Given this list of marker genes Pdcd1, Ptpn11, Trbv16, Trav16, Trav19, Pdcd1lg2, H2-Eb1, Cd3d, Cd3e, H2-Ab1, Csk, Cd3g, H2-Aa, Ptpn6, Cd247, Cd4, H2-Ea, Trbv15, Lck, H2-Eb2, Cd274, Trac, here is a description of the gene set: species: Mus musculus Co-inhibition by PD-1 Mouse Gene Set: REACTOME_CO_INHIBITION_BY_PD_1